Given this list of marker genes Avpr1b, Plaa, Apoc2, Ang5, Agtr1a, Apoc2l, Ang, Ccn1, Ccl5, Fgfr3, Agtr1b, Arhgap6, Fgfr2, Ang6, Pla2g5, Ang4, Ang2, here is a description of the gene set: studied in species Mus musculus Mouse Gene Set: GOBP_POSITIVE_REGULATION_OF_PHOSPHOLIPASE_ACTIVITY Any process that increases the frequency, rate or extent of phospholipase activity, the hydrolysis of a phospholipid.